The following is a description of a gene set: studied in species Homo sapiens Any process that modulates the frequency, rate or extent of GABAergic synaptic transmission, the process of communication from a neuron to another neuron across a synapse using the neurotransmitter gamma-aminobutyric acid (GABA). Human Gene Set: GOBP_REGULATION_OF_SYNAPTIC_TRANSMISSION_GABAERGIC, and this is the list of marker genes: DRD2, TACR1, KCNK2, CLN3, ADORA1 (adenosine A1 receptor), PHF24, STXBP1, CNTNAP4, PLCL2, TAC1, CA7, ADRA1A, ADORA2A, NF1, NPS, NLGN2, KRAS, KIF5B, CNR2, HAP1, BAIAP3, SYN3, CA2, SLC38A1, NPAS4, USP46, ZDHHC12 (zinc finger DHHC-type palmitoyltransferase 12), NRXN1, NPY5R, ZDHHC3, NLGN1, NALCN, PLCL1, PRKCE